Given this list of marker genes ALMS1, RET, GPR101, MMP14, SASH1, MINPP1, AIP, FOXE1, HABP2, DICER1, MMP2, KEAP1, MAD1L1, here is a description of the gene set: Nodular goiter Human Gene Set: HP_NODULAR_GOITER Enlargement of the thyroid gland related to one or more nodules in the thyroid gland. studied in species Homo sapiens